Given this list of marker genes ATP1B1, GNAL, TENT4B, UBE2E2, ZNF41, IMPG2, MSL2, FBXO3, DIAPH3, ZNF624, PPP3R1, EPB41L4B, RER1, PAN3, YWHAG, PKP2, MS4A12, BAAT, CTSC, SNX10, DACH1, ANKRD27, GCH1, RC3H1, SOX2, GRK5, NEXN, COL24A1, LRRC58, EPN2, SLC39A3, ONECUT2, KLHL2, ZBTB41, TREM1 (triggering receptor expressed on myeloid cells 1), HEY2, NAP1L1, SINHCAF, ZNFX1, WDCP, ALS2, RSF1, DDX4, NAPG, IGF1, NOTCH3, LPAR6, HOOK3, BTBD8, TFDP1, AGFG1, CTBP2, DCAF10, SEC14L1, USP33, STRN3, PPTC7, AHR, PI4K2B, BBX, KIF5B, PIK3AP1 (NCBI Gene Id 118788), CDK14, NUP98, WDFY4, CXCL5, LYSMD2, ZNF451, PRRC1, TFAP2A, ZSWIM7, ATOSA, DSTYK, MRPL17, CARD8, RSBN1L, TRMT11, FARP1, CDH11, KBTBD6, TBPL1 (NCBI Gene Id 9519), MGST2, SLC24A2, GHITM, NR2F1, ZNF558 (zinc finger protein 558), GABPA, RSRP1, CSTF2T, AK4, XRCC2, IPMK, DDX3X, BPNT2, MAGI2, MITF, LEPROT (leptin receptor overlapping transcript), PRKCI, ETV6, DIDO1, CDKL5, ABLIM1, HLF, CNOT6, DAAM1, CNR1, ZNF680, LIMA1, YWHAQ (tyrosine 3-monooxygenase/tryptophan 5-monooxygenase activation protein theta), CCER1, SPTY2D1, EAF1, PCDH9, ESRP2, FEM1C, CCPG1, NIPAL1, RGS7BP, SLC5A3, DPY19L4, SLIT2 (NCBI Gene Id 9353), SH3RF3, GRM5 (NCBI Gene Id 2915), NR4A3, TRIM13, ELAVL2, USP11, PDE6D, FAM91A1, PSMA5 (proteasome 20S subunit alpha 5), HDAC9, VDAC1, SLC4A4, PRUNE2, COG6, ERO1A, SPMIP4, CEP63, PTCHD1, KIAA1549L, PADI1, EOGT, HYAL4 (hyaluronidase 4), CCL17, SUPT7L, OSBPL8, ZDHHC15, ZNF594 (zinc finger protein 594), LIN28B, AAK1, SSR1, AKT3, TRIM5, SUCO, PHTF2, here is a description of the gene set: from publication Chen Y, Wang X (PMID 31504780) Human Gene Set: MIR548U Genes predicted to be targets of miRBase v22 microRNA hsa-miR-548u in miRDB v6.0 with MirTarget v4 prediction scores > 80 (high confidence targets). species: Homo sapiens